Given this list of marker genes SIX1, SIX5, COL5A1, CCNQ, CHD7, C12orf57, IGBP1, EYA1, SALL1, here is a description of the gene set: Lop ear studied in species Homo sapiens Anterior and inferior folding of the upper portion of the ear that obliterates triangular fossa and scapha. Human Gene Set: HP_LOP_EAR